Given this list of marker genes PTCH1, PKD2, CD34, WNT1, HES1, ACAT1, YAP1, NOTCH2, TGFB1, MYC, SMO, WNK4, FGF8, IRX1, EDNRB, EXT1, DLL1, AGT, UMOD, SOX8, HS3ST3B1, PAX2, TMEM59L (NCBI Gene Id 93030), BASP1, KLHL3, ILK, BCL2, EDN1, GREM1, BMP4, AQP11, LIF, CTNNB1, KLF15, AGTR2, FOXC2, ADAMTS16, FGF1, POU3F3, FOXJ1, MTSS1, CALB1, HS2ST1, CD24, PROM1, HEYL, WNT9B (Wnt family member 9B), AHI1, WNT11, PECAM1, WNT4, KIF26B, FOXD1, NOG, LAMB2, WWTR1, PTPRO, NOTCH1, EYA1, HS3ST3A1, LHX1, CITED1, OSR1, SIX2, GZF1, MYO1E, BMP2, PODXL, SOX9, ASXL1, SMAD4, HOXB7, DCHS1, GATA3, STAT1, CD2AP, FOXC1, WNT6, DLG1, NPHS1, PKD1, GPC3, MEF2C, JAG1, IRX3, WNT7B, NPNT, EDNRA, MAGI2, IQGAP1, IRX2, SLC22A1, SIX4, LAMA5, HNF1B, VEGFA, GREB1L, HES5, SIX1, SHH, TFAP2B, CTNNBIP1, AQP1, TACSTD2, FGF2, AMPD2, LGR4, SALL1, TCF21, PAX8, GLI3, WNT2B, HOXD11 (homeobox D11), MAGED1, NPHS2, PBX1, HOXA11, SLC22A6, LZTS2, ADIPOQ, GDNF, WT1, here is a description of the gene set: Human Gene Set: GOBP_NEPHRON_EPITHELIUM_DEVELOPMENT The process whose specific outcome is the progression of the nephron epithelium over time, from its formation to the mature structure. An epithelium is a tissue that covers the internal or external surfaces of an anatomical structure. The nephron epithelium is a tissue that covers the surface of a nephron. studied in species Homo sapiens